Given this list of marker genes MTCO1P17, BICD1P1, ANKRD44, KRT18P39, H3P8, LINC01857, SUMO1, C2orf80, MIR7845, ORC2, PSMA2P3 (proteasome subunit alpha 2 pseudogene 3), NPM1P33, VPS26CP1, MIR2355, LINC01877, CRYGD, MAIP1, ENSG00000295187, MTCO3P16 (NCBI Gene Id 107075155), STRADB, C2orf66, C2orf69, SNORD11, BZW1-AS1, RN7SL670P, RNA5SP116, MTND4LP16, TRAK2, WDR12, MTCO1P54, RNU6-360P, MYOSLID-AS1, RNU7-45P, RPL39P14, CYP20A1, COQ10B, MARS2, RNU6-31P, UBE2V1P11, CRYGA, SNORD11B, MTND3P16, CMKLR2, MTND5P31, MIR3130-1, INO80D-AS1, SGO2, SF3B1, BZW1, RNY4P34, RPL27P8, ABI2, BOLL, MTND5P25 (MT-ND5 pseudogene 25), HNRNPA1P51, MTCO2P16 (MT-CO2 pseudogene 16), HSPE1, ENSG00000289422, MTATP6P16, MIR3130-2, PGAP1, RNU6-651P, RPL7P14, RNU6-664P, ATP5POP1, CPO, ADAM23, RNU7-147P, PLEKHM3, NOP58, PPIAP68, ENSG00000287524, AOX1, BMPR2, RN7SKP178, RNA5SP115 (RNA, 5S ribosomal pseudogene 115), HSPE1-MOB4, CD28, RNU6-440P, NDUFS1, NBEAL1, ATP5MC2P3, CASP10, ENO1P4, HNRNPA1P35, MIR1302-4, MTND4P23, RN7SKP200, ENSG00000232732, INO80D, NRP2, MOB4, DAZAP2P1, RNU6-1029P, RN7SL717P, C2CD6, MTATP6P17, GTF3C3, CCNYL1, SNORD51, AOX2P, SNORD70B, KIAA2012-AS1, RPL4P7, KLF7-IT1, LINC01802, RFTN2, LINC03097, FAM237A, GCSHP3, CARF, TMEM237, MTCO2P17, CCDC150, MYOSLID, RN7SL753P, CTLA4, AOX3P-AOX2P, KCTD18, ACER2P1, CASP8, CFLAR-AS1, PARD3B, FLACC1, CLK1, CRYGC, HMGN1P6, SNORA41, ALS2, RN7SKP260, NIF3L1, RPL12P16, CDK15, PLCL1, ICOS, MTND3P17, CREB1, RNU6-312P, RPS2P16, LINC01923, RPL23AP36, RPL12P17, HSPD1, PPIL3, KRT8P52, DYTN, MTND4LP17, SNORD70, FASTKD2, CMKLR2-AS, SATB2-AS1, NPM1P46, EEF1B2, CRYGEP, KIAA2012, CRYGB, NDUFB3, ANKRD44-IT1, ENSG00000202434 (novel transcript), RPL13AP12, FZD5, IMPDH1P10 (inosine monophosphate dehydrogenase 1 pseudogene 10), SPATS2L, RPL9P14, SEPHS1P6, MDH1B, MTCO3P17, RPL23AP30, ANKRD44-AS1, MIR4775, CFLAR (CASP8 and FADD like apoptosis regulator), METTL21A, HNRNPA3P15, RAPH1, PPP1R14BP2 (protein phosphatase 1 regulatory inhibitor subunit 14B pseudogene 2), RNU1-133P, KLF7, MRPL50P2, ENSG00000202059, PIMREGP1, FZD7, NRP2-AS1, KRT8P15, RPL38P5, LINC01792, RPL17P10, FTCDNL1, TYW5, ICA1L, MTND4P30, AOX3P, MTND4P29, RNU6-1206P, RPS29P9, DSTNP5, FAM117B, ENSG00000252923, RNU6-762P, SCYL2P1, RN7SL40P, ANKRD44-DT, ZDBF2, HYCC2, MTND4LP13, SATB2 (SATB homeobox 2), MPP4, RNU6-474P, here is a description of the gene set: studied in species Homo sapiens Human Gene Set: chr2q33